Given this list of marker genes Fbxo11, Mettl23, Prmt7, Prmt3, Ndufaf7, Prmt6, Carm1, Prmt5, Prmt9, Prmt1, Prmt2, Prmt8, here is a description of the gene set: Catalysis of the reaction: S-adenosyl-L-methionine + (protein)-arginine = S-adenosyl-L-homocysteine + (protein)-N-methyl-arginine. Mouse Gene Set: GOMF_PROTEIN_ARGININE_N_METHYLTRANSFERASE_ACTIVITY species: Mus musculus